The following is a description of a gene set: Human Gene Set: UNTERMAN_IPF_VS_CTRL_MONOCYTE_UP studied in species Homo sapiens Genes upregulated in Monocytes from Idiopathic Pulmonary Fibrosis Patients vs. Controls Thirty-eight PBMC samples from 25 patients with IPF and 13 matched controls yielded 149,564 cells that segregated into 23 subpopulations. Classical monocytes were increased in progressive and stable IPF compared to controls (32.1%, 25.2%, 17.9%, respectively, p<0.05). Total lymphocytes were decreased in IPF vs controls, and in progressive vs stable IPF (52.6% vs 62.6%, p=0.035). Tregs were increased in progressive vs stable IPF (1.8% vs 1.1% of all PBMC, p=0.007), although not different than controls, and may be associated with decreased survival (P=0.009 in Kaplan-Meier analysis; P=0.069 after adjusting for age, sex, and baseline FVC). Flow cytometry analysis confirmed this finding in an independent cohort of IPF patients. Fraction of Tregs out of all T cells was also increased in two cohorts of lung scRNA-seq. CCL22 and CCL18, ligands for CCR4 and CCR8 Treg chemotaxis receptors, were increased in IPF. The single-cell atlas of the peripheral immune system in IPF, reveals an outcome-predictive increase in classical monocytes and Tregs, as well as evidence for a lung-blood immune recruitment axis involving CCL7 (for classical monocytes) and CCL18/CCL22 (for Tregs). (From Abstract) from publication Unterman A, Zhao AY, Neumark N, Schupp JC, Ahangari F, Cosme C Jr, Sharma P, Flint J, Stein Y, Ryu C, Ishikawa G, Sumida TS, Gomez JL, Herazo-Maya JD, Dela Cruz CS, Herzog EL, Kaminski N (PMID 38717443), and this is the list of marker genes: CCL4, CTSD, S100A12, CCL5, FOLR3, PPBP, THBS1, S100A8, IL1R2, FKBP5, CD163, MYL9